The following is a description of a gene set: Fibers, composed of actin, myosin, and associated proteins, found in cells of smooth or striated muscle. species: Homo sapiens Human Gene Set: GOCC_CONTRACTILE_MUSCLE_FIBER, and this is the list of marker genes: SYNE1 (spectrin repeat containing nuclear envelope protein 1), TPM2, CRYAB, NRAP, PSMA6, ALDOA, MYH15, SLC2A1, SYNC, ABCC9, MYL5, KCNN2, TMOD4, CMYA5, MYL1, SLMAP, ACTN1, OBSL1, TUFT1, LRRC39, COL6A1, PRICKLE4, MYL12B, SCN3B, ACTN4, KLHL41, SYNE2, FRG1, PDLIM1, MYH11, ITGB1BP2, TNNC2, MYBPC3, PGM5, JUP, CSRP3, PDLIM3, ATP2B4, TRIM54, MYH6 (NCBI Gene Id 4624), BIN1, TWF1, MYH7, PDE4B, MYBPH, PDLIM2, MYBPHL, SCN1A, DES, PDLIM4, PPP2R5A, PECAM1, DST, CACNA1C, FBP2, MYLK2, MYH4, MYOD1, MYOZ3, DNAJB6, NPNT, SYNPO, JPH1, FKRP, SYNPO2, LDB3, MYL4, CSRP2, S100A1, DCTN4, CORO1C (coronin 1C), PPP1R12A, MYOT (myotilin), HSPB1, SMN1, TCAP, CAB39, CACNA1S, CAV3, CASQ1, ARF1, ACTA1, CTNNB1, TWF2, RYR3, BMP10, SORBS2, ACTN3, KCNN1, SIMC1, SMN2, MYH1 (NCBI Gene Id 4619), KCNE1 (NCBI Gene Id 3753), C10orf71, CASQ2, FLNB, LMAN1, GGPS1, KRT8, DNAJB4, MMP2, NOS1, CACNA1D, PARVA, LMOD2, PDE4DIP, SPTBN1, MYL3, FBXO22, SCO2, RTN2, ANK3, FXR1, FERMT2, FHOD3 (NCBI Gene Id 80247), TRIM32, SDC4 (NCBI Gene Id 6385), MYH3, OBSCN, FLNA, ANKRD23, ATP2A1, FKBP1A, IGFN1, PAK1, TPM1, CALD1 (NCBI Gene Id 800), VCL, REM1, ANKRD1, TMOD3, ACTN2, HOMER1, HRC, KCNA5, MYL11, KCNN3, FKBP1B, PYROXD1, HABP4, MTMR12, MYO18B, SLC4A1, MYZAP, MYL9, PPP1R12B, FBXO32, LMOD3, KCNJ8 (NCBI Gene Id 3764), KY, SLC8A1, TRIM63, ACTC1, SRI, MYH2, TNNI2, TMOD2, MYH7B, FHL5, PPP3CA, SMTNL1, ABRA, JPH2 (NCBI Gene Id 57362), SCO1, MYH13, SYNM, MTM1, KLHL40, NEXN, SCN8A, FHL2, ANKRD2, KAT2B, LMOD1, ASB2, NEBL, TNNI3, ILK, TNNT1, PDLIM5, TNNT3, XIRP2, SMPX, MYBPC1, DAG1, MYH8, AHNAK, UNC45B, DMD, PLEC, FLNC, CALM2, TNNC1, ACTG1, PRKD1, PVALEF, CAVIN4, TMOD1, MYL2, TNNT2, ARHGEF25, TPM3 (tropomyosin 3), IDO1, CFL2, CDK5R1, STYXL2, KCTD6, GLRX3, MYPN, TTN, CALM1, MYOZ2, FHL3, ADPRHL1, MYOZ1, STUB1, MYOM3, SYNPO2L, CALM3, NOS1AP, POLR2M, KRT19, RYR1, NBR1, MYBPC2, BAG3, ANK2, AKAP4, LRRC10, DEK, MYOM2, SVIL (NCBI Gene Id 6840), ENO1, CAPZB, MYOM1, SQSTM1 (sequestosome 1), MYL6B, NEB, PDLIM7 (PDZ and LIM domain 7), TPM4, TNNI1, ACTA2, SCN5A, MYL7, PPP3CB, FBXL22, PARVB, RYR2, CSRP1 (cysteine and glycine rich protein 1), ANK1, CAPN3, PALLD